The following is a description of a gene set: Notch signaling pathway. Pathway ID: N00086. Pathway type: Reference. Pathway class: nt06511 NOTCH signaling. Human Gene Set: KEGG_MEDICUS_REFERENCE_NOTCH_SIGNALING_PATHWAY species: Homo sapiens Pathway Definition from KEGG: (DLL,JAG) -> NOTCH -> (NICD+RBPJ) => (HES1,HEY1), and this is the list of marker genes: DLL1, RBPJ, JAG2, HEY1, NOTCH3, JAG1, DLL4, RBPJL, NOTCH2, NOTCH4, DLL3, HES1, NOTCH1